Given this list of marker genes Angptl3, Angptl8, Angptl4, Apoc3, Apoc1, Sort1, here is a description of the gene set: species: Mus musculus Any process that stops or reduces the activity of the enzyme lipoprotein lipase. Mouse Gene Set: GOBP_NEGATIVE_REGULATION_OF_LIPOPROTEIN_LIPASE_ACTIVITY